The following is a description of a gene set: Mouse Gene Set: GOBP_NEGATIVE_REGULATION_OF_FILOPODIUM_ASSEMBLY studied in species Mus musculus Any process that stops, prevents, or reduces the frequency, rate or extent of the assembly of a filopodium, a thin, stiff protrusion extended by the leading edge of a motile cell such as a crawling fibroblast or amoeba, or an axonal growth cone., and this is the list of marker genes: Rab3ip, Prkcd, Arhgap44, Capzb, Nrxn1